Given this list of marker genes IGFALS, SETBP1, STAT4, TFAP2A, PPP1R15B, GNA11, SOS2, KCNJ6, SMC3, CYP2R1, HDAC8 (NCBI Gene Id 7492), ACTB, SYNE1, DNAJC19, HLA-DQB1, CDC42, CDAN1, COLEC11, PAM16, PCNT, FLNC, MASP1, DCX, NRAS, SOS1, TNNI3, NAE1, HLA-DQA1, PTRH2, MYH3, ERCC8, ANKRD55, UQCC3, XYLT1, NEXMIF, CDK10, RNF31, KMT2A, SV2A, SHPK, SMC1A, ERCC6, FOXP2, DOCK11, MRAS, MCTP2, PLCB4, BRAF, H19, TBCE, RPL10, ADAMTS3, SMARCE1, TMCO1, MTX2, SLC5A2, PLAG1, INSR, SPRED2, EP300, TRMT10A, CBL, FAT4, FAM111A, ADAMTS2, BLM, CTNNB1, SOX11, FGFRL1, COLEC10, WFS1, TAF6, ATR, FIG4, SEC24D, SMARCA4, HMBS, ATP6V0A2, ARID1A, TNNT2, PHKB, SMARCB1, PAPPA2, SIX6 (SIX homeobox 6), SPTB, SALL4 (spalt like transcription factor 4), RRAS, IL2RB, B3GALT6, RFXAP, SNRPB, CACNA1C (calcium voltage-gated channel subunit alpha1 C), SLC2A1, NBAS, KRAS, PSPH, CYP11B2 (cytochrome P450 family 11 subfamily B member 2), KIF20A (kinesin family member 20A), NSD2 (NCBI Gene Id 7468), GNPTAB, DHODH (dihydroorotate dehydrogenase (quinone)), MYPN, RIT1, PRIM1, CPLX1, TGDS, PIEZO2, PTPN22, PHKG2, NALCN, TCEAL1, RAB18, IL2RA, COQ7, DBR1, ATRX, SMARCC2, NDE1, TBC1D20, CHD7 (chromodomain helicase DNA binding protein 7), ARID2, ANKRD17, ARG1, COG1, MED12, GYPC, CCDC22, POU1F1, BRIP1, KDM6A, EPB41, SEMA3E, ERCC4, RNU4ATAC, BRD4, MEG3, PLAGL1, UFSP2, RYR1, IGF2, NIPBL (NIPBL cohesin loading factor), MTRR, LZTR1, DPF2, LMNA, GJB2, PCYT1A, WASHC5, RAB3GAP2, BNC2, TUBB3, IARS1 (NCBI Gene Id 3376), ESCO2, CASK, RAF1, SIN3A, MGAT2, SOX2, CKAP2L, GINS1, TCF4, KIF7, PTPN2 (protein tyrosine phosphatase non-receptor type 2), EBP, CD247, DDX11, FLNA, B3GLCT, COG4, TSHB, GUSB, DMXL2, EPG5, RTEL1, PLOD3 (procollagen-lysine,2-oxoglutarate 5-dioxygenase 3), ELAC2, DLK1, DPYSL5, SMOC1, NEK8, OCRL (NCBI Gene Id 4952), SLC9A3, CDKN1C, RPS6KA3, RAD21 (RAD21 cohesin complex component), KMT2D, NSUN2, COG7, RERE, RPL13 (NCBI Gene Id 6137), EMG1, THRB, PYGL, NIN, KANSL1, GRB10, ARSL, PALB2, ARID1B, MCM4, FBLN5, MBD5, CTBP1, VPS35L, RRAS2, CREBBP, TRAPPC2, ATP9A, MAF, ATP6V1A (ATPase H+ transporting V1 subunit A), ROBO1, HMGA2 (high mobility group AT-hook 2), LARP7, VAC14, RASA2, CYP27B1, PRKAR1A, GHSR, GJB6, PTPN11, CHD1, CEP295, SLC2A2, MAP2K1, HYMAI, RNPC3, PDE4D (NCBI Gene Id 654081), RTL1 (retrotransposon Gag like 1), ALDH18A1 (aldehyde dehydrogenase 18 family member A1), BUB1B, SOX4, SLC4A2, CCBE1, POU3F4, SCUBE3, TOMM7, FOSL2, ATP6V1E1, SMARCD1, FRA10AC1, GATA3, TAF1 (TATA-box binding protein associated factor 1), DDX3X, GM2A, MYCN, STAT5B, SLC19A1, NAA10, SATB2, CUL7 (cullin 7), KIF15, CTC1 (CST telomere replication complex component 1), LHX4, DYM (NCBI Gene Id 54808), IGF1, LIG4 (NCBI Gene Id 3981), EBF3, LETM1, ELN, AKR1D1, SPTA1, here is a description of the gene set: species: Homo sapiens Human Gene Set: HP_POSTNATAL_GROWTH_RETARDATION Postnatal growth retardation Slow or limited growth after birth.